The following is a description of a gene set: Human Gene Set: GOMF_RNA_POLYMERASE_I_TRANSCRIPTION_REGULATORY_REGION_SEQUENCE_SPECIFIC_DNA_BINDING Binding to a specific sequence of DNA that is part of a regulatory region that controls the transcription of a gene or cistron by RNA polymerase I. studied in species Homo sapiens, and this is the list of marker genes: UBTF, PIH1D1, SMARCB1, UBTFL6, CEBPA, RRN3, BAZ2A, TAF1C, UBTFL1, TBP, SMARCA4, TAF1B